Given this list of marker genes SC5D, DHCR24, DHCR7, EBP, here is a description of the gene set: studied in species Homo sapiens part of: Cholesterol biosynthesis Reactome Pathway: Cholesterol biosynthesis from zymosterol (modified Kandutsch-Russell pathway) Tracer studies in intact mice and human and mouse cell lines showed little flux through the complete KR pathway in any tissue. Instead, a modified form of the pathway was observed, in which delta(24)-sterol reductase (DHCR24) reduced zymosterol (ZYMOL), a Bloch pathway intermediate, to zymostenol (ZYMSTNL), a KR intermediate, which was then metabolized via the last three steps of the KR pathway to form cholesterol. Usage of this pathway was observed in skin, preputial glands and brain.